Given this list of marker genes FOXD1, PAX8, SIX4, PAX2, MYC, LGR4, ADIPOQ, WNT2B, BASP1, MAGED1, AGTR2, RET (NCBI Gene Id 5979), BMP4, NOG, TGFB1, WT1, GDNF, SIX1, WNT4, SOX9, CITED1, GREM1, SMO, SIX2, LHX1, BMI1, SOX8, PPP3CA, OSR1, GATA3, VEGFA, HNF1B, AGT, STAT1, HOXB7, TACSTD2, EZH2, here is a description of the gene set: species: Homo sapiens Any process that modulates the rate, frequency or extent of kidney development. Kidney development is the process whose specific outcome is the progression of the kidney over time, from its formation to the mature structure. The kidney is an organ that filters the blood and excretes the end products of body metabolism in the form of urine. Human Gene Set: GOBP_REGULATION_OF_KIDNEY_DEVELOPMENT